The following is a description of a gene set: species: Homo sapiens from publication Chen Y, Wang X (PMID 31504780) Human Gene Set: MIR7704 Genes predicted to be targets of miRBase v22 microRNA hsa-miR-7704 in miRDB v6.0 with MirTarget v4 prediction scores > 80 (high confidence targets)., and this is the list of marker genes: COA8, SMURF1, ETS1, LEF1, GNG3, EEF1A2